Given this list of marker genes MMP2, SOD1, NOX1, MCL1, ADCY10, VNN1, SFPQ, FBXW7, PARK7, here is a description of the gene set: Human Gene Set: GOBP_POSITIVE_REGULATION_OF_OXIDATIVE_STRESS_INDUCED_INTRINSIC_APOPTOTIC_SIGNALING_PATHWAY Any process that activates or increases the frequency, rate or extent of an oxidative stress-induced intrinsic apoptotic signaling pathway. studied in species Homo sapiens